Given this list of marker genes Hrh4, Adra2a (NCBI Gene Id 11551), Oprm1, Cd55 (CD55 molecule, decay accelerating factor for complement), Avpr1a, Opn4, Xcr1 (NCBI Gene Id 23832), Adrb1, Kiss1, Sstr2, Taar9, C3ar1, Sstr4, Drd2, Galr1, Tas2r139, Gng3, P2ry13, Hrh2, Npy4r, Drd5, Ccl11, Ptgdr2, Pth1r (parathyroid hormone 1 receptor), Gnrhr, Grm4 (glutamate receptor, metabotropic 4), Ptger4, Aplnr (NCBI Gene Id 23796), F2, Ucn3, Tas2r144, Tshr, Chrm3, Gng11 (NCBI Gene Id 66066), Gpr35, Tas1r2, Adm, Cxcr5, Eef1ece2, Mc5r (NCBI Gene Id 17203, melanocortin 5 receptor), Taar1, Gal, Ccl12, Adgre5, Htr4, Plppr1, Hrh1, Adcyap1, Npff, Lpar6, Htr6, Hcar2, F2rl3 (F2R like thrombin or trypsin receptor 3), Npy1r, Hrh3, Cxcr3, Agtr2, Htr1a, Gnb5, Ackr2, Fpr-rs7, Cxcl2, Gpr17, Crhr1, P2ry10 (purinergic receptor P2Y, G-protein coupled 10), Htr7, Sstr1, Gngt2, Tas2r131, Ccr10, Ccr4, Cxcr2, Ccl5, Gprc6a, Crhr2, Mc2r, Tas2r135, Gpr4, Qrfprl, Edn1, Tas2r120, Opn1sw, Fshb, Gabbr1, Cxcl16, Grp, Ccl21a, Gpr65, Plppr5 (NCBI Gene Id 75769), Ffar1, Hcrt, Bdkrb1, Cmklr1, Tas2r130, Nts, Npy2r, Taar8b (trace amine-associated receptor 8B), Kng2, Ccl3, Ffar3, Uts2b, Trh, Rln3, Brs3, Oxtr, Adra2b, Rxfp4, Ccl17, Ghrh, Mtnr1a, Insl5, Npw, Cck, Vipr2, Galr2, Prokr2, Sucnr1, Nms, Htr2c, Gcgr, Sctr, Adra1a, Ccl7, Hcrtr1, Ccl20, Rxfp2, Prok1, S1pr4, Avp, Gpr132, Ntsr1, Cga (glycoprotein hormones, alpha subunit), Cx3cr1, Gng10, Ucn2, Oxt, P2ry1, Ackr4, Penk, Fpr1, Tas2r137, P2ry4, Nmur1, Chrm4, Taar8c, Cxcl10, Rgr, Chrm1, Gng4, Avpr2, Pth2, Gpha2, Oprd1, Tacr1, Bdkrb2, Opn3, Nmb, S1pr5, Psap, Npffr1, Ppy, Galr3, Ptgir, Crhbp, Tas2r108, Nmur2, Hcar1, Drd4, Ccr7, Ghrhr, Gng7, Ramp3, Adrb3, Mc4r, Tas1r3, Pnoc, Grpr, Opn5, Hc, Qrfp, Hcrtr2, Cckbr, Glp1r, Npsr1, Ltb4r1, Gip, Trhr, Tacr2, F2rl1, Cnr1, Lpar4, Glp2r, Ptger2, Prok2, Ffar2, Gnb2, Kel, Fpr-rs4, Ucn, Ntsr2, Iapp, Gng8, Cysltr2, Prokr1, Cxcr1, Ccl4, S1pr3, Fpr-rs6, Oxgr1, Ccl21e, Gpr143, Sst, Gngt1, Tas2r121, Htr1b, Rho, Ccl21f, Tas2r105, Tac2, Sct, Tas2r138, Pf4, Tas2r107, Ptgdr, Sstr3, Taar3, Ccl6 (C-C motif chemokine ligand 6), Chrm2, C5ar1 (NCBI Gene Id 12273), Npb, Rxfp3, Fshr, Ccl9, Pyy, C3, Cxcl3, Ednrb, C5ar2, Taar5, Mc3r, Edn3, Avpr1b, Gipr, Tas2r126, Edn2, Casr, Vipr1, Gnb3, Prlhr, Lpar5, Drd3, Cysltr1, Ccr3, Cxcl12 (NCBI Gene Id 20315), Cckar, Adm2, Gng5, Cnr2, Gphb5, Ptger1 (prostaglandin E receptor 1 (subtype EP1)), Oprl1, Htr1f, Cxcr4, Pomc, Gpr183, Lpar3, Fpr-rs3, Tas2r119, Ccr6, Rrh, Gper1, Plppr3, Gcg, Nmu, Mchr1, Gpbar1, P2ry2, Gpr68, Tas2r136, Cort, Ccl19, Cxcr6, Uts2, Ece1, Htr5a, Ccr8, Adora2a, Tbxa2r, Hebp1, Cxcl9, Cxcl1 (NCBI Gene Id 14825), Pth2r, Mc1r, Kiss1r, Uts2r, Tas2r118, Adra2c, Vip, Lpar2, Ccl28, here is a description of the gene set: electronically inferred by orthology from the curated human pathway part of: Signaling by GPCR species: Mus musculus Reactome Pathway: GPCR ligand binding This event has been computationally inferred from an event that has been demonstrated in another species.<p>The inference is based on the homology mapping from PANTHER. Briefly, reactions for which all involved PhysicalEntities (in input, output and catalyst) have a mapped orthologue/paralogue (for complexes at least 75% of components must have a mapping) are inferred to the other species.